The following is a description of a gene set: species: Homo sapiens Human Gene Set: GOBP_NEGATIVE_REGULATION_OF_CATECHOLAMINE_SECRETION Any process that stops, prevents, or reduces the frequency, rate or extent of the regulated release of a catecholamine., and this is the list of marker genes: ADRA2B, CRH, ADRA2A, ADRA2C, P2RY1, ABAT, CHGA, DRD2, SYT11, SYT4, GHSR, GABBR1